Given this list of marker genes UCP2, AGPAT2, MAPT, PTPN22, CHAT, RERE, YY1, NEXMIF, SYNGAP1, RFX7, MEN1, SETD2, LEP, MAN1B1, SOX11 (SRY-box transcription factor 11), LUZP1, MC4R, SMARCC2, SLC12A3, DNM1, NTRK2, GABRD, GPR101, MN1, CLCNKB, BBS9, PGM2L1, IL6, SLC5A7, ADCY3, MAGEL2, SMARCA4, SLC2A3, SOX4, SLC25A1, MBD5, LEPR, EZH2, PACS1, ZFX, ELP2, POMC, SYT2, CASZ1, TRANK1, SH2B1, BRAF, NKX2-1, ADNP, PRDM16, SNORD116-1, SKI, LARP7, IFT74, ZNF699, ZSWIM6, SPEN, SRRM2, AGRN, SMARCD1, ASH1L, DPYD, BSCL2, SLC3A1, CRELD1, KCNAB2, OFD1, GRB10, CTNNB1, SLC18A3, CDK13, PDPN, UBE4B, SCN4A, ITPR3, PWRN1, ATP10A, CHD8, UBE3A (ubiquitin protein ligase E3A), ACAT1, SLC25A13, TAF4, HERC2, ACBD6, SMARCE1, DHPS, MMP23B, COL13A1, PCSK1, SNAP25, OCA2, HNF1A, KCNJ10, PDSS1, SLC7A7, HSPG2, SNORD115-1, KCNJ11 (NCBI Gene Id 3767), DPF2, RNU4-2, ARID1B, GRN, SLC5A2, GNAS, PLA2G6, PRKCZ, MEIS2, ABCC8, CACNA1A, VAMP1, SATB2, PWAR1, SUPT16H, MYT1L, MKRN3, NPAP1, PSEN1, NDN, ATP5F1B, SIM1, ALMS1, HTT, PCDH19, MYO9A, SMARCB1, PREPL, SNRPN, ARID1A, ARID2, here is a description of the gene set: Human Gene Set: HP_ABNORMAL_EATING_BEHAVIOR Abnormal eating habits involve excessive or insufficient consumption of food, or any other abnormal pattern of food consumption. studied in species Homo sapiens Abnormal eating behavior